Given this list of marker genes YAP1, HIPK2, HIPK1 (homeodomain interacting protein kinase 1), GATA4, TEAD3 (NCBI Gene Id 7005), TEAD2, KAT2B, CCN2, TEAD4, RUNX2, NKX2-5, TBX5, NPPA, WWTR1 (WW domain containing transcription regulator 1), TEAD1, here is a description of the gene set: species: Homo sapiens Human Gene Set: REACTOME_YAP1_AND_WWTR1_TAZ_STIMULATED_GENE_EXPRESSION YAP1- and WWTR1 (TAZ)-stimulated gene expression